The following is a description of a gene set: Catalysis of the hydrolysis of ester linkages within nucleic acids. Mouse Gene Set: GOMF_NUCLEASE_ACTIVITY studied in species Mus musculus, and this is the list of marker genes: Rnasek, Dclre1b, Rnaset2b, Mre11a, Nme1, Ercc4, Ear10, Ang6, Cwf19l1 (CWF19 like cell cycle control factor 1), Exd2, Mus81, Fan1, Pms2, Alkbh3, Zc3h12d, Elac1, Mblac1, Rcl1, Fen1, Tatdn3, N4bp2, Nme8, Drosha, Nme7, C1qbp, Rpp38, Piwil1, Exosc3, Rps3, Ear14, Piwil2 (piwi-like RNA-mediated gene silencing 2), Dna2, Enpp1, Slfn14, Aptx, Ercc5, Tdp2, Eri3, Endou, Ang, Pnldc1, Zc3h12a, Meiob, Xrcc3, Rnase11, Rexo2, Rnaset2a, Lactb2 (lactamase, beta 2), Plscr2, Slfn2, Dis3l, Ints11, Aplf, Pnpt1, Rad1, Parn, Prorp, Dffb, Tsn, Dxo, Pan3, Fancm, Toe1, Ear2, Eri2, Wrn, Alkbh2, Slfn1, Ang4, Rnase10, Slfn4, Rnaseh1, Rnasel, Cnot1, Rbbp8, Rnase13, Exo5, Ern2, G3bp1, Eme1, Pop7, Rnase6, Xrn2, Endov, Eri1, N4bp1, Usb1, Enpp3, Cnot6, Pold1, Dnase1, Ankzf1, Mrpl44, Samhd1, Slfn9, Rnase1, Rpp14, Apex2, Rpp25, Ago3, Rnase12, Pld4, Pgbd5, Dis3l2, Xrcc4, Endod1, Abce1, Enpp2, Pld3, Nudt16l1, Nme5, Nudt12, Isg20, Tsnax, Rnaseh2a (ribonuclease H2, large subunit), Cnot6l, Ear6, Dis3, Dnase1l3, Dffa, Cpsf3, Exd1, Exosc10, Polg, Khnyn, Dynll1, Rad51c, Dnase2a, Dclre1a, Tmbim6, Polq, Trex2, Polrmt, Rnase4, Ddx1, Gen1, Dbr1, Apex1, Tdp1, Cnot8, Myg1, Setmar, Smg6 (NCBI Gene Id 216951), Rexo1, Slfn8, Pde12, Rpp21, Ang5, Endog, Helz2, Exo1, Gm28729, Nynrin, Slfn3, Pan2, Rida, Rad9a, Ear1, Dicer1, Tsen34, Ago4, Rad50, Aen, Pole, Rpp40, Exog, Xrn1, Dnase1l2, Isg20l2, Bivm, Ern1, Dnase1l1, Rexo4, Slx1b, Cnot7, Rag1, Rnase2a (NCBI Gene Id 93726), Rnh1, Nudt16l2, Trir, Elac2, Harbi1, Nob1, Ago2, Pop1, Plscr1, Aste1, Zc3h12b, Cnot2, Dclre1c, Piwil4, Ang2, Snd1, Rnase2b, Rnase9, Noct, Zranb3, Tatdn1, Eme2, Tsen2, Rpp30, Pld6, Xrcc1, Pop4, Marf1, Trex1, Ankle1, Ercc1, Mgme1, Pop5, Dnase2b, Ybey, Zc3h12c, Nudt16, Rexo5, Dcp2, Las1l, Ptbp1